Given this list of marker genes Camk2a, Rabep1, Gdi1, Htt, Anks1b, Ogt, Sh3gl2, Senp7, C9orf72, Lrrk2, Fmr1, Prkcg, Tnk2, Sumo2, Prkce, Pias3, Marcksl1, Sumo3, Sncb (synuclein, beta), Ppfia2, Ppp3cc, Ube2i, Hnrnpab, Senp6, Syt1, Ctbp2, Stxbp5, Erc1, Sumo1, Baiap2, Prkca (NCBI Gene Id 18750), Hap1, Calm2, Usp14, Pias1 (protein inhibitor of activated STAT 1), Trim9, Senp5, Stxbp1, Ppt1, Ncs1, Fus, Fbxo45, Pnkd, Senp1, Calb1 (calbindin 1), Marcks, Hspa8, Arl6ip5, Prkcb, here is a description of the gene set: Mouse Gene Set: GOCC_PRESYNAPTIC_CYTOSOL The region of the cytosol consisting of all cytosol that is part of the presynapse. species: Mus musculus